The following is a description of a gene set: Thyroxine biosynthesis Mouse Gene Set: REACTOME_THYROXINE_BIOSYNTHESIS studied in species Mus musculus, and this is the list of marker genes: Tpo, Dio1, Cga, Tshb, Duox1, Dio3, Slc5a5, Iyd, Duox2 (dual oxidase 2)